The following is a description of a gene set: Mouse Gene Set: MIR_7657_5P species: Mus musculus Genes predicted to be targets of miRBase v22 microRNA mmu_miR_7657_5p in miRDB v6.0 with MirTarget v4 prediction scores > 80 (high confidence targets). from publication Chen Y, Wang X (PMID 31504780), and this is the list of marker genes: Sorbs2, Dnaja1, B3galt2, Il7, Pate2, Afp, Smad5, Rnf38, Mlxip, Ppp1r3a, Kifc1, Lrrtm3, Ccdc88a (NCBI Gene Id 77927), Slc30a6, Cdk17, Zfp260, Ptprc, Zpbp, Msl2, F830016B08Rik, Ccdc7a, Vegfa, Spx, Fbrsl1, Ifi203, Hmgn1, Kctd4, Nrep, Tbc1d31, Hook1, Rad21